Given this list of marker genes Ubqln4, Mad2l2, Rif1, Radx, Smchd1, Polq, Fancb, Senp3, Abl1, Kat5, C1qbp, Trp53bp1, Rmi2, Shld3, Plk1, Fbh1, Shld2, Parpbp, Cgas (cyclic GMP-AMP synthase), Csnk2a1, Klhl15, Recql5, Helb, Kmt5a, Shld1, here is a description of the gene set: studied in species Mus musculus Any process that stops, prevents, or reduces the frequency, rate or extent of double-strand break repair via homologous recombination. Mouse Gene Set: GOBP_NEGATIVE_REGULATION_OF_DOUBLE_STRAND_BREAK_REPAIR_VIA_HOMOLOGOUS_RECOMBINATION